The following is a description of a gene set: Human Gene Set: HP_SQUARE_FACE Square face species: Homo sapiens Facial contours, as viewed from the front, show a broad upper face/cranium and lower face/mandible, creating a square appearance., and this is the list of marker genes: MYCN, WAC, DEAF1, IFT57, FLII, OSTM1, CHD7, SETD1B, RAI1, KDM5B, ADAMTSL1, IQSEC2, PUF60, EP300, LIFR, CREBBP